Given this list of marker genes MEIS1, AKAP10 (NCBI Gene Id 11216), SLC6A11, HYDIN, SPTBN1, RAP1GDS1, LINC03105, TRABD2B, SCN3A, ST7, PRLR, ITGA9, USP1, TNFRSF11B, CDH9, HNMT, SH3RF1, NIF3L1, SNTG1, NTNG1, CUL3, PLPP6, NUDCD2, PIK3R4, TLR4, MOB4, SKIDA1, INPP5E, SCAMP1, GNPDA2, PIEZO2, CADM3, NEGR1, DIP2B, HSPE1-MOB4, VAMP4, PCSK5, TRIM50, CLOCK, ATRX, ENSG00000277067, POC1B, SCN2A, TMEM202, DLX1, HIVEP1, PGR, NHS, FKBP7, LINC03104, YTHDF3, BOLA3, WWP2, SCML2, TIMM8A, CSF2, TCF4, NR4A3, AP2B1, DTD2, PHIP, PDCD10, ZNF26, CRTC3, C2orf66, GABPA, FMR1, SLC20A2, TADA2B, PALLD, ANXA4, SMARCA4, RINL, CREB1, TTC7B, CCDC88A, GRIA2, PAPPA, SCLT1, HIBADH, PEX3, SLC30A7, IDI2, SMARCAD1, UACA, ZNF566, here is a description of the gene set: from publication Chen Y, Wang X (PMID 31504780) Genes predicted to be targets of miRBase v22 microRNA hsa-miR-5583-3p in miRDB v6.0 with MirTarget v4 prediction scores > 80 (high confidence targets). Human Gene Set: MIR5583_3P species: Homo sapiens